Given this list of marker genes DRG2, RSBN1, CUL1, DPAGT1, SNX30, DFFB, NUBP2, ZBTB14, SMIM30, METTL18, EMSY, FNTA, MLKL (mixed lineage kinase domain like pseudokinase), TIMM22, TUFM, COQ6, RPLP2 (ribosomal protein lateral stalk subunit P2), TCF3, FAM3C, TMBIM4, CSTF3, TUBGCP5, MT2A, REX1BD, SEC11A, DLD, RAI1, ZC3H13, RPS6KA3, ZNF692, CA12, SIAE, PPIA, ABL2, USP7, ELOF1, GOLPH3L, ACO1, MYLK, EIF4A1, PWP1, PKMYT1, HARBI1, TWNK, TACC1, MRPL46, EEF1AKMT1, DPP3, INO80, TMEM129, PSMC5, TUT1, NAP1L4, GATB, ATAD1, PPP1R8, PUS3, SDR39U1, CCNYL1, PDK1, MRPL14 (NCBI Gene Id 64928), RMND1, ARMCX6 (armadillo repeat containing X-linked 6), DYNC2I1, TCEAL1, BTBD3, PNO1, RTF1, THYN1, IMP4, HERC2, YIPF5, FKRP, DHPS, TAF6, PANK4, NDUFAF4, UTP15, GP5, FANCB, CSNK2A2, DHX16, EIF5A2, AAMP, CCDC115, KEAP1, ABT1, ITPR3, ZNF260, RPTOR, GTPBP3, TUBA8, ERO1B, TLCD1, ZNF280C, CLDN12 (NCBI Gene Id 9069), CCDC122, SCARF1, CNEP1R1, MLLT1 (NCBI Gene Id 56930), BRCA1, FBXL19, COL4A2, ADI1, WIPI2, SNAPC2, POLE, GMCL1, CHURC1, BLOC1S5, ZC3H14, KHDRBS3, AREL1, EFR3A, ATPSCKMT, IMMP1L, DDIAS, OPA1, LSM1, CCDC51, DALRD3, TSR3, GUF1 (GTP binding elongation factor GUF1), ZNF213, HMMR (hyaluronan mediated motility receptor), CIAO1, NDUFA9, BST2, ZNHIT2, EXOG, FASTKD5, PEX11A, DEPTOR, MIS18A, YRDC, NT5C, FRA10AC1, MARS2, SMARCD2, TDP1, CYP4V2, RAD18, DNAJB11, MEN1, ZNG1B, NDE1, COMMD5, P4HB, LRRC42, SLC35C2, SF3A3, FRS2, RPS6KB1, PDCD7, MCOLN2, NUP93, MARCHF5, MGME1, TMEM14A, FXR1, ATF5, EMC2, NUP35, DBP, PDIA4, RGS1, CHORDC1, GATA3, PPM1K, ZDHHC8, EXTL3, KRT18, ATP5F1B, PIM3, NBN, CALHM6, DHX9, RLIG1, BBS12, ARMCX4, PSMA7, PKP4 (NCBI Gene Id 8502), CEP76, ABHD14A, UCK1, LONRF3, PTP4A2, SNRPC, DHX32, ACLY, AAMDC, HMGN3, SDHA, FANCM, IER3IP1, PSMB4, ARB2A, RTCA, HRAS, MRPL37, here is a description of the gene set: Human Gene Set: GSE18893_CTRL_VS_TNF_TREATED_TCONV_2H_DN from publication Nagar M, Jacob-Hirsch J, Vernitsky H, Berkun Y, Ben-Horin S, Amariglio N, Bank I, Kloog Y, Rechavi G, Goldstein I (PMID 20181891) species: Homo sapiens Here we show that tumor necrosis factor (TNF) induced in human T-regulatory cells (Treg), as compared to conventional T cells (Tcon), a transcription program highly enriched for typical NF-κB target genes, such as: the cytokines LTA and TNF; the TNF-receptor super family members FAS, 4-1BB and OX-40; various anti-apoptotic genes; and other important immune-response genes. As an initial approach to examine the cellular program induced by TNF in Tregs versus Tcon cells, we employed microarray gene expression analysis at 2 and 24 hrs following TNF treatment. Genes down-regulated in T conv cells (2h): medium versus TNF.